Given this list of marker genes HGF, MET, here is a description of the gene set: Reactome Pathway: Drug-mediated inhibition of MET activation MET receptor tyrosine kinase (RTK) is a proto-oncogene that is frequently aberrantly activated in cancer through gene amplification and/or activating mutations that result in hypersensitivity to HGF stimulation or HGF-independent activation. Oncogenic MET activation can occur as a primary mechanism of malignant transformation or be selected secondarily, as a mechanism of resistance to therapeutics that target related RTKs, such as EGFR. MET targeted anti-cancer therapeutics, either recombinant monoclonal antibodies (MAbs) or small tyrosine kinase inhibitors (TKIs), have shown promise as a first-line agents for the treatment of solid tumors with primary MET activation or as second-line agents for the treatment of solid tumors with acquired MET-mediated resistance to other RTK-targeted therapies. studied in species Homo sapiens part of: Negative regulation of MET activity